Given this list of marker genes OCRL, SYNJ1, SYNJ2, PTPRQ, INPP5E, PIKFYVE, FIG4, here is a description of the gene set: Human Gene Set: GOMF_PHOSPHATIDYLINOSITOL_3_5_BISPHOSPHATE_5_PHOSPHATASE_ACTIVITY species: Homo sapiens Catalysis of the reaction: phosphatidylinositol-3,5-bisphosphate + H2O = phosphatidylinositol-3-phosphate + orthophosphate.